Given this list of marker genes H2bc12, H4c6, H4c3, Kat5, H2bc11, Paxip1, H2bc27, Rnf168, Lig4, H4c18, H4c11, Pias4, Ube2n, Mdc1, H2bc13, H2ax, Bard1, Tdp2, H4c12, Babam1, Mre11a, H4c14, H2bc22, H4c1, H4c8, Brcc3, H4c9, H4c4, Polm, Nhej1, H2bc15 (H2B clustered histone 15), H2bc3, H2bc7, H4c2, H4c17 (H4 clustered histone 17), H2bc8, Trp53bp1, H2bc9, Nbn, Brca1, Xrcc6, H2bc1, Prkdc, here is a description of the gene set: electronically inferred by orthology from the curated human pathway Reactome Pathway: Nonhomologous End-Joining (NHEJ) This event has been computationally inferred from an event that has been demonstrated in another species.<p>The inference is based on the homology mapping from PANTHER. Briefly, reactions for which all involved PhysicalEntities (in input, output and catalyst) have a mapped orthologue/paralogue (for complexes at least 75% of components must have a mapping) are inferred to the other species. part of: DNA Double-Strand Break Repair species: Mus musculus